The following is a description of a gene set: from publication Chen Y, Wang X (PMID 31504780) studied in species Homo sapiens Human Gene Set: MIR3941 Genes predicted to be targets of miRBase v22 microRNA hsa-miR-3941 in miRDB v6.0 with MirTarget v4 prediction scores > 80 (high confidence targets)., and this is the list of marker genes: SYBU, DIP2B, KLHL23, MOSPD1, AJAP1, GCSAML, POU2F1, KRIT1, CYP2R1, HAUS2, NAP1L2, FAM120C, IKZF5 (IKAROS family zinc finger 5), KITLG, IRS1 (NCBI Gene Id 3667), RAB6B, DACT1, PTPN2, CDC73, ZNF584, OFD1, DLAT, MON2, LY6G5C, PDE10A, ZNF667 (NCBI Gene Id 63934), SORT1, ABCB10, UBA6, MAP3K7CL, TSEN34, TCP1, PCMT1, GRIK2, SMCHD1, ABI1, ANKRD45, KDM7A, WDR26, AZI2, RADX, DAAM1, AHCTF1, RUNX2, LEMD3 (LEM domain containing 3), MRPL49, ZCCHC24, KLHL2, TIAM1, SGSM2, GSK3B, GRB2, CPSF6, MPDZ, CCDC112, MOB4, TENT4B, NDUFS5, NAPEPLD, TNRC6B, RNF144B, SNRK, FAM184A, MCAM, EPSTI1, YEATS4, USP9X, ZNF706, RBPJ, RNF19A, CEP70, RIC3, CEP350, SORBS2, PLCXD1, CSNK1D, ALG10B, DENR, SPATA17, SSBP2, TMEM108, CRLF3, PRPF39, HYCC2, PSIP1, PROS1, FBN1, HSPA13, UBR1, ENSG00000255537, PRR23C, KRAS, APC, PPM1H, ADCY9, SEC31A, ZNF786, ATF7IP, SORL1, MECP2, ZNF268, ASH1L, ATAD2, NRBF2, TESPA1, FBXO4, ENPP4, IL36G, ARID2, CENPBD1P, SIAH1, DCLK1, SLF2, ATP2C1, RNF19B, DCX, KIF13A (NCBI Gene Id 63971), VAPA, VAMP2, CDC14A, KIAA1143, SGMS2, PCDH18, PPP1R13B, TCEAL7, STARD8, BAHCC1, HS6ST2 (NCBI Gene Id 90161), EDIL3, KDM2A, RAI1, METTL9, KANSL1L, KLHL9, OSBPL11, PDS5A, P2RY1, COL23A1, FLVCR1, PWWP2A, RHNO1, VAV3 (NCBI Gene Id 10451), CREB5, RUNX1T1 (NCBI Gene Id 862), SHB, TMEM167A, ZBTB41, BPNT2, DDX52, NAA16, EYA4, BMF, PDE3A, SOCS6, MTMR9, KHDRBS2, ZEB1, DPYSL2, SP4, CCP110, CDK1, PAM, TFAP2C, PCDH11X, DLGAP4, EBF2, MOSMO, TP53INP1, WDR72 (WD repeat domain 72), PPP4R2, NLK, SYTL4, C22orf39, ZBTB14, PNPT1, RNF216 (ring finger protein 216), SLC6A19, ST6GAL2, R3HDM1, ING2, LRRTM4, THUMPD1, SGIP1, TP53BP1, ZFHX3, TSPAN14, KLC1, DARS1, LARP4, KLF15, LRP2BP, INPP5A, SDC2, CARF, MAPRE1, HHIP, CYP51A1, CELF2, UBE2K, FEZF1, PITPNB, HIPK1, MBL2, CFAP61, ZMAT3, TOP1, PDZD8, FAM135B, SHROOM2 (shroom family member 2), LBH, PTBP2, ASXL1 (ASXL transcriptional regulator 1), SLITRK4, IL17RA, PHF21A, CORIN, PSME4, NREP, SPIN1, NR2C2, PCSK2, TNPO1, ANAPC4, ANKRD40, TMEM196, HSPE1-MOB4, KHDRBS1, KDM5C, SLC4A7, AP5M1, DENND5B, NHS, UBE2D2, FUT9, RTF1, PCBD1, PPP2R2C, TOPBP1, SLC39A2, PHLDA1, CCDC28A-AS1, CLVS2, VGLL4, CLCN4, RMND5A, RNF138, SLC8A1, KLF6, PAX5, GOLGA7, TOX, BRWD3, VSTM2A, RORA, UBR5, RBM41, ZNF281, ETV1, PLAG1, SRGAP3, ZNF544, U2SURP, FBXO45, EME1, PNRC1, NAP1L3 (nucleosome assembly protein 1 like 3), PRRG1, AMER2, SEC22C, FREM2, HERC2, STEAP2, ADCYAP1, WNT1, RAB1A, STRBP, SAP18, PDK4, ZNF283, WSCD2, LILRB2, NYAP2, AFF3, USP37, JAG2, LRAT, NR3C1, KCNH5, PSD3, FAT3, ZC3H6, PI15, MID1, MGAT4A, DYNLL2, AFTPH (aftiphilin), PCBP1, PEAK1, USP9Y, WDR47, PARVA, STBD1, PTEN, STK17B, BEND7, ANKFY1, FBXO5, PIK3C2A, MTPAP, ABCA5, ELAVL4, ZNF169, RNF139, IKZF2, ANK3, KIT, NCKAP1, HOOK1, MMS22L, INO80D, AURKA, PGR, TBX5, GABRB2, ARID1B, TENT5A, SLC44A1, UCK2, RASGRP1, CYB5R4 (NCBI Gene Id 51167), FAM3C, TIMM10B, CENPI, PAXBP1, NSG1, GUCY1B1, CNTN3, ADAMTS9, STARD13, GPR137C, PITPNM3, BCL6, RTL5